Given this list of marker genes LDB3, SLC24A1, POGZ, TLE4, HEY1, HSPE1-MOB4, ZNF197, MOB4, WAPL, ATAD2, PAIP1, MAPK14, TET3, WAC, CTNNA2, TNFAIP8L2, MAN2A2, MLLT6, CLCN2, PPP4R3A, CNBP, NUFIP2, QRICH1, PASD1, SEMA3G, HMGXB3, HOXA1, NRXN3, B4GALT2, EMP1, KIF5C, SPTB, PARM1 (NCBI Gene Id 25849), SMURF2, HNRNPU, PIEZO2, SMG5, PSD3 (NCBI Gene Id 55358), KHDRBS1, SETD5 (NCBI Gene Id 55209), UEVLD, UBAP2L, ZDHHC22, HS3ST1, TBC1D16, ACVR2B, SPTBN4, CA6, ELMO2, MED18, ACTR1B, PCDH19, GTF2A1, GABRB2, POLDIP3, FAN1, MYT1, PDE7A, TSTD2, IL20RB, MAST3, UBE2K, MARCHF9, PHETA1, TAF4B, ZNF704, CHN1, GABBR1, BLCAP, TWIST1, HEPHL1, POTEM, CXXC4, SOX9, HMGB1, ATF6B, TMEM65, PIM1, VAV2, DCP2, OTUD7B, HEG1, NELL1, GNG2, PSMA1, PDCD4, NSD1, KDM2A, IPO7, EVI2A, CALN1, TMEM33, GCFC2, PPM1N, ARFGAP2, SNX1, HOXA9, ATG14, EHF, NCMAP, here is a description of the gene set: from publication Chen Y, Wang X (PMID 31504780) Human Gene Set: MIR6826_3P studied in species Homo sapiens Genes predicted to be targets of miRBase v22 microRNA hsa-miR-6826-3p in miRDB v6.0 with MirTarget v4 prediction scores > 80 (high confidence targets).